The following is a description of a gene set: species: Homo sapiens from publication Chen Y, Wang X (PMID 31504780) Human Gene Set: MIR9851_3P Genes predicted to be targets of miRBase v22 microRNA hsa-miR-9851-3p in miRDB v6.0 with MirTarget v4 prediction scores > 80 (high confidence targets)., and this is the list of marker genes: GALNT13, OTUD4, CCND1, KIAA1143, SLC25A44, SRGAP3, SIRPA, SEMA4D, OGT, GRM1, TRPM3, ATF7IP, PAM, ARMC7 (armadillo repeat containing 7), FBXL5, LDLRAP1, PI15, MMD2, CTDSP1, FGF9, AZIN1, CEP43, RPP30 (ribonuclease P/MRP subunit p30), IKZF2, OSBPL11, MYO5B, SPOCK3, CACNA2D2, CDC42SE2, SEC24D, CAMTA1, SPOUT1, PSD3, FKBP9, PSEN2, CCND2, ARK2C, FBXW11, TET1, ELMO2, EPB41L4B, JHY, YOD1, SPSB1, COMMD7, L3MBTL3, UBTD2, CELSR3, TMEM163, SLC12A9, TET3, PDE6C, RGPD2, STX17, EIF4EBP2, DAZAP2, ARL8B, SLC26A7, PTP4A1, ETV1, B3GALT1, IQCK, TLCD3A, MYO18A, VKORC1L1, XIAP (NCBI Gene Id 8257), ADSS2, SERTAD4, HDAC7, NFYB, DCUN1D2, MAP3K20, CCDC190, FZD5, PDE3A, SPRY3, SLC7A8, ASAP2, ARFGAP2, FLOT2 (NCBI Gene Id 2319), ARHGAP21 (NCBI Gene Id 57584), HCN1, CYGB, SRSF10, GNAI3, FUT8, GTDC1, JPT2, PIK3C2A, KRT74, IDH2, FAF2 (Fas associated factor family member 2), CEP170B, RIMS4, RNMT, ZNF695, IL17RD, GRIK4, KIF13A, UGT8, HP1BP3, EGR1, RALB, TMEM214, CMTM4, TWSG1, ST6GALNAC4, SERF2, DOP1A, RPP14 (ribonuclease P/MRP subunit p14), PLK3, TMEM117, STK36, RNF152, NEMP1, FMC1-LUC7L2, WDR82, INPP5A, FRMD5, FOXO1, GLRX3, HS3ST5, CARHSP1, HADH, WIPF1, MSN, OTUD7A (NCBI Gene Id 161725), NRG2 (neuregulin 2), COL11A1, LSMEM2, DNAJC3, OVOL1, PAFAH1B1, PTPDC1, KLF6, TTYH3, SOCS7, MTSS1, LUC7L2 (NCBI Gene Id 51631), CSMD1, NEUROD4, KLHL24, MYO1B, LNX2, HEATR1, PCDH7, STK26, ANKRD44, USP49, DUSP18, FOXK2, RPS6KA6, C12orf60, DLX5, SP1, CDCA7L, ROBO2, ARHGEF12 (NCBI Gene Id 55406), NDST1, AMMECR1L (NCBI Gene Id 83607), ZDHHC17, MBNL3, OVOL2, PLEKHF2, SH2B3, FBXO41, ANKRD40, ZFPM2, LRCH2, OGFOD2, NXN, TIMP3, DPP8, RNF19A, NCDN, SNX1, MAP4K5, ZNF496, CAV1, CHIC2, TOR3A